Given this list of marker genes RANBP1, AURKB, NDC80, KIF20A, RNASEH2A, BUB1, ASPM (assembly factor for spindle microtubules), MCM3, ASF1B, RFC3, TPX2, BIRC5, CDCA8, ESPL1, PA2G4, TRIP13, SMC2, CCNA2, MCM6, CCT4, RAN, ATIC, KIF2C, MRPL35, CKS1B, NCAPD2, IARS1, RPA3, PAICS, CENPE, MELK, RFC4, TCP1, CDC20, KIF11, GMPS, UBE2C, here is a description of the gene set: Human Gene Set: GNF2_CKS1B Neighborhood of CKS1B CDC28 protein kinase regulatory subunit 1B in the GNF2 expression compendium Neighborhood of CKS1B species: Homo sapiens